Given this list of marker genes Pth1r, Avpr1b, Ppip5k2, Ippk, P2ry6, Snca, Prkg1, Adcyap1r1, Itpkb, Ntsr1, Ptafr, Ip6k1, Ppip5k1, Pou1f1, Cd244a, Ip6k2, Plcg2, Ip6k3, Itpka, Plek, Gper1, Plcd1, Plcg1, P2ry1, Pth, Ipmk, Myh9, Lhcgr, Mas1, Scp2, Itpkc, here is a description of the gene set: Mouse Gene Set: GOBP_INOSITOL_PHOSPHATE_BIOSYNTHETIC_PROCESS The chemical reactions and pathways resulting in the formation of an inositol phosphate, 1,2,3,4,5,6-cyclohexanehexol, with one or more phosphate groups attached. species: Mus musculus